Given this list of marker genes FHL1 (NCBI Gene Id 2273), PTPRZ1, PGM1, SLC7A5, SCRN1, TMED10, SDHA, SLC2A1, MTHFD2, R3HDM1, MT2A, VEGFA, MYC, LAMB1, FLNB, BRD3, FASN, LAMA3, PTPRK, KIFAP3, PRDX6, COL17A1, THBS2, TNFSF10, SEMA3C, ALCAM, REEP5, PFKP, CSNK2A2, TTC3, CCND2, MRPS27, ME1, PUDP (pseudouridine 5'-phosphatase), COL5A2, EPRS1, DSC1 (desmocollin 1), PFN2, FXR1, ID3 (inhibitor of DNA binding 3), PPP2R5A, SEPTIN8, TMEM131, APP, EPHA4, GLG1, PPP3CA, DST, GJB2, ITPK1, SORL1, PON2, GTF2I, ST6GALNAC2, FBN2, RFC1, GLB1, LTBP1, PTPRF, ALDH9A1, CYFIP1, SERPINE1, HK1, IL4R, TOMM20, FDFT1, MYH10, ITGA3, STK3, FGFR3, CTNNA1, here is a description of the gene set: Cluster 8: genes changed in primary keratinocytes by UVB irradiation. Human Gene Set: SESTO_RESPONSE_TO_UV_C8 from publication Sesto A, Navarro M, Burslem F, Jorcano JL (PMID 11867738) species: Homo sapiens UV radiation is the most important environmental skin aggressor, causing cancer and other problems. This paper reports the use of oligonucleotide microarray technology to determine changes in gene expression in human keratinocytes after UVB treatment. Examination of the effects of different doses at different times after irradiation gave a global picture of the keratinocyte response to this type of insult. Five hundred thirty-nine regulated transcripts were found and organized into nine different clusters depending on behavior patterns. Classification of these genes into 23 functional categories revealed that several biological processes are globally affected by UVB. In addition to confirming a majority up-regulation of the transcripts related to the UV-specific inflammatory and stress responses, significant increases were seen in the expression of genes involved in basal transcription, splicing, and translation as well as in the proteasome-mediated degradation category. On the other hand, those transcripts belonging to the metabolism and adhesion categories were strongly downregulated. These results demonstrate the complexity of the transcriptional profile of the UVB response, describe several cellular processes previously not known to be affected by UV irradiation, and serve as a basis for the global characterization of UV-regulated genes and pathways.